Given this list of marker genes CCNA1, PKMYT1, CCNB2, CCNB1, WEE1, CDK1 (cyclin dependent kinase 1), CCNA2, here is a description of the gene set: part of: G2/M Checkpoints The G2/M DNA replication checkpoint ensures that mitosis is not initiated until DNA replication is complete. If replication is blocked, the DNA replication checkpoint signals to maintain Cyclin B - Cdc2 complexes in their T14Y15 phosphorylated and inactive state. This prevents the phosphorylation of proteins involved in G2/M transition, and prevents mitotic entry.<p>Failure of these checkpoints results in changes of ploidy: in the case of mitosis without completion of DNA replication, aneuploidy of <2C will result, and the opposite is true if DNA replication is completed more than once in a single cell cycle with an overall increase in ploidy. The mechanism by which unreplicated DNA is first detected by the cell is unknown. Reactome Pathway: G2/M DNA replication checkpoint species: Homo sapiens